The following is a description of a gene set: studied in species Mus musculus Mouse Gene Set: GOBP_ROUNDABOUT_SIGNALING_PATHWAY The series of molecular signals initiated by a SLIT protein binding to a Roundabout (ROBO) family receptor on the surface of a target cell, and ending with the regulation of a downstream cellular process, e.g. transcription., and this is the list of marker genes: Slit3, Mir218-1, Myo9b, Slit2, Mir218-2, Robo1, Rhoa